Given this list of marker genes SMYD5, KDM5A, BCL6, SIN3A, SUZ12, H2AC16, H2AZ1, CBX1, KMT2D, MORC2, RIF1, MBD2, SCMH1, SMARCAD1, DYRK1A (dual specificity tyrosine phosphorylation regulated kinase 1A), H2AC25, PIWIL4, H2AC17, PARTICL, MACROH2A1, CDYL, MACROH2A2, PPHLN1, MORC1, RLF, H1-9P, PCGF5, TDRD1, EHMT2, PPM1D, H2AC15, H2AZ2, ARB2BP, HDAC2, SMARCA5, MBD3L2B, MECP2, HNRNPK, H2AC20, H3-3A, SPIN1, MOV10L1, RBM15, LMNB2 (NCBI Gene Id 84823), KAT8, HNRNPU, SUV39H1, PHF2, SPTY2D1, SMARCA2, SMARCA1, HDAC8, LMNB1, SIRT2, TNP1, TDRD9, BEND3, METTL3, BAZ2A, UBR2 (ubiquitin protein ligase E3 component n-recognin 2), HDAC1, L3MBTL1, SPEN, H2AC12, TEX15 (NCBI Gene Id 56154), RESF1, KMT2A, CDK2, CBX5, MAEL (maelstrom spermatogenic transposon silencer), DNMT3L, H2AJ, SETDB1 (NCBI Gene Id 9869), RRP8, TDRD5, SIRT1, TASOR, HMGA2, HAT1 (NCBI Gene Id 8520), CENPV, HELLS, MBD3L1, BAZ1A, LMNA, MPHOSPH8, HMGB1, LRIF1, H2AC19, UHRF1, H2AC4, DNMT1, SIRT6, H2AP, TRIM28, MBD1, MBD3L5, SMARCA4, BMI1, DDX4, PHF8, ARB2A, BAP1, TDRD12, TPR, H2AC6, BRCA1, EZH2, SPOCD1, PIWIL2, ATRX, EHMT1, DNMT3A (DNA methyltransferase 3 alpha), ATF7IP, H1-0, C19orf84, H2AX, H2AL3, RBM15B, MIS18A, H2AC11, H2AB3, TRIP12, H2AB2, H2AC7, H2AB1, MBD3, LBR, BAHD1, XIST, EED, H2AC8, EZH1, RLIM, DOT1L, PIWIL1, RB1, H2AC13, MBD3L3, PTENP1-AS, HDAC3, YTHDC1, UBR5, SMCHD1, PCGF3, CBX3, NRDE2, H1-2, ZNF304, CIZ1, FKBP6, H2AC21, POLE3, MBD3L2, ZNFX1, H2AC18, CDKN2B-AS1, CTCF, JARID2, MBD3L4, H2AC1, H3-3B, here is a description of the gene set: An epigenetic gene silencing mechanism in which chromatin is compacted into heterochromatin, resulting in a chromatin conformation refractory to transcription. This process starts with heterochromatin nucleation, its spreading, and ends with heterochromatin boundary formation. studied in species Homo sapiens Human Gene Set: GOBP_HETEROCHROMATIN_FORMATION